The following is a description of a gene set: from publication Gu X, Zerbini LF, Otu HH, Bhasin M, Yang Q, Joseph MG, Grall F, Onatunde T, Correa RG, Libermann TA (PMID 17483333) Human Gene Set: GU_PDEF_TARGETS_UP species: Homo sapiens The epithelium-specific Ets transcription factor, PDEF, plays a role in prostate and breast cancer, although its precise function has not been established. In prostate cancer, PDEF is involved in regulating prostate-specific antigen expression via interaction with the androgen receptor and NKX3.1, and down-regulation of PDEF by antiproliferative agents has been associated with reduced PDEF expression. We now report that reduced expression of PDEF leads to a morphologic change, increased migration and invasiveness in prostate cancer cells, reminiscent of transforming growth factor beta (TGFbeta) function and epithelial-to-mesenchymal transition. Indeed, inhibition of PDEF expression triggers a transcriptional program of genes involved in the TGFbeta pathway, migration, invasion, adhesion, and epithelial dedifferentiation. Our results establish PDEF as a critical regulator of genes involved in cell motility, invasion, and adhesion of prostate cancer cells. Integrin, VEGF, Wnt and TGFbeta signaling pathway genes up-regulated in PC-3 cells (prostate cancer) after knockdown of PDEF by RNAi., and this is the list of marker genes: SDC1, ITGA6 (integrin subunit alpha 6), PTK2, CDH18, COL4A1, PLCG1, LAMB2, SNAI2, FZD4, LEF1, DOCK1, RAC2, ZEB1 (NCBI Gene Id 6935), TCF4, CDH2, VEGFB, FN1, SDC2, FZD8, TGFBI, PIK3CD, TGFB1, HDAC1, HIF1A, COL6A1, SMAD3, PLCE1, MAPK9, COL4A5, DOCK10, COL13A1, COL6A2 (collagen type VI alpha 2 chain), CCN2, CDH11 (NCBI Gene Id 1009), COL1A1, TCF3, SMAD2, SERPINB7, COL5A1, COL4A6, PIK3C3, BMP2, COL5A2, DOCK4, TNC (tenascin C), COL6A3, MAPKAPK2, LAMC1, SERPINA1, SERPINI1, LAMC2, DKK3, VEGFA, COL4A2, PRKCA, MAPKBP1, COL16A1, SERPIND1, ITGA5, SMAD1, SMAD4 (NCBI Gene Id 4089), SERPINB3, RAC3, WIPF1, MAP4K4, VIM, FZD1, SERPINE1, PLCB4, ITGA3, WNT5A